The following is a description of a gene set: from publication Müller FJ, Laurent LC, Kostka D, Ulitsky I, Williams R, Lu C, Park IH, Rao MS, Shamir R, Schwartz PH, Schmidt NO, Loring JF (PMID 18724358) Stem cells are defined as self-renewing cell populations that can differentiate into multiple distinct cell types. However, hundreds of different human cell lines from embryonic, fetal and adult sources have been called stem cells, even though they range from pluripotent cells-typified by embryonic stem cells, which are capable of virtually unlimited proliferation and differentiation-to adult stem cell lines, which can generate a far more limited repertoire of differentiated cell types. The rapid increase in reports of new sources of stem cells and their anticipated value to regenerative medicine has highlighted the need for a general, reproducible method for classification of these cells. We report here the creation and analysis of a database of global gene expression profiles (which we call the 'stem cell matrix') that enables the classification of cultured human stem cells in the context of a wide variety of pluripotent, multipotent and differentiated cell types. Using an unsupervised clustering method to categorize a collection of approximately 150 cell samples, we discovered that pluripotent stem cell lines group together, whereas other cell types, including brain-derived neural stem cell lines, are very diverse. Using further bioinformatic analysis we uncovered a protein-protein network (PluriNet) that is shared by the pluripotent cells (embryonic stem cells, embryonal carcinomas and induced pluripotent cells). Analysis of published data showed that the PluriNet seems to be a common characteristic of pluripotent cells, including mouse embryonic stem and induced pluripotent cells and human oocytes. Our results offer a new strategy for classifying stem cells and support the idea that pluripotency and self-renewal are under tight control by specific molecular networks. studied in species Homo sapiens Human Gene Set: MUELLER_PLURINET Genes constituting the PluriNet protein-protein network shared by the pluripotent cells (embryonic stem cells, embryonical carcinomas and induced pluripotent cells)., and this is the list of marker genes: ARID3B, MNAT1, STRBP, GDF9, BYSL, RAD54L, PLSCR1, APOE, NUDT1, RFC4, NCL, POU5F1, CTBP2, MYB, TRIP13, PXN, SNRPE, PTPN6, TNNI3, HSPA8, TP53, MCM2, NPM1, NME1-NME2, PFDN6, NTAQ1, VAMP8 (vesicle associated membrane protein 8), ARMC6 (armadillo repeat containing 6), GRB7, MTHFD1, RUVBL1, MATK, RAD9A, KPNB1, LSM6, SMARCAD1, CHEK1, PARP1, EXOSC3, BRIX1, NLE1, MT1G, FBP1, BLM, DDX11, GAR1, SRSF3, POLQ, SYNCRIP, PHGDH, NTHL1, LUC7L3, H2BC4, SP1, STIP1, PFN1 (profilin 1), PCYT1B, BAK1, STXBP2, EPPK1, SNRPC, HPRT1 (NCBI Gene Id 3251), CCND1, MRPS12, PNN, WEE1, CKS1B, TDP2, MYC, CCNE1, DNMT3B, NUP50, NANOG, PSME3, DCTPP1, FUBP1 (far upstream element binding protein 1), OTX2, NOP56, ERBB3, HMGA1, ZNF281, EXOSC7, PNP, PCNA, WDR33, TUBA3C, LCK, CCNB1, TARBP2, SPAG5, PBX1 (NCBI Gene Id 5087), ZNF165, ERCC5, UNC119, MSH2, MCM6, GTF2H2, PSMA3, FOXO4, PSIP1, EWSR1, RMND5B, RPA2, PTMA, MCM3, SNRPN, POLR1D, EXOSC8, FKBP3, CDA, MYBBP1A, COIL, SNURF, TGIF1, PPM1B, CASP6, COPS3, DSCC1, FBL, TCOF1, PALS2, PA2G4, CDT1, ZNF593, HSPA9, DHFR, LSM1, ANAPC1, HAUS1, ORC1, GMNN, NPPB, KPNA2, PAK1, APEX1, GNL3, SEPHS1, POLR1C, GMPS, SIRT1, U2AF1, PRMT5, LRIF1, NOC2L, POP5, BUB1B, RFC5, COPS6, SNRPA, HSPA14, RAD51, BAG6, HDAC2 (NCBI Gene Id 3066), SMNDC1, CDC25C, CDK7, ANP32A, GPRIN2, DAXX, SNRPB, ANXA2, SRSF2, PAK3, RASL11B, RFC2, STXBP3, DAZAP1, MYBL2, WDR77, RBM14, MBD2, POLG2, TCERG1, SOCS1, MUTYH, GEMIN7, SUPT3H, ANXA3, RPA1, DPPA2, CEBPZ, TOE1, PPAN, RND1 (NCBI Gene Id 27289), HMMR, EXOSC9, ARL4A, HMGB1, HNRNPK, ITGB3BP, PHF10, ATIC, TNFRSF8, BIRC5, POP7, LSM4, PMF1, DIAPH1, CASP9, BCL2, MRM3, PMAIP1, EXO1, SSB, CXADR, CDC7, NME1, MCM10, MSH3, PLPP2, CRIPTO, AIMP2, ORC6, RECQL4, ACTA1, GOT2, HSPD1, GEMIN6, CDK1, CCNB2, TK1, MRE11, CCNA2, SNRPF, ELAC2, ZFP42, SUMO1 (small ubiquitin like modifier 1), SNRPD1, FAM136A, POLD1, DHCR24, TRIM28, PPID, LSM7, PASK, ORC2, KIT, RCHY1, TPX2, AURKA, HSPH1, PSMA6, LSM5, RFC3, PRNP, PHC1, CDC45, MCM5, SRSF1, HSP90AB1, KAT7, BIK, BCCIP, WRN, HDAC1, MSH6, STX3, SIGLEC12, SMN1, SALL4, AURKB, TMSB4Y, NUP153, MCM4 (NCBI Gene Id 780917), PIAS2 (protein inhibitor of activated STAT 2), LSM3, SET, PHB1, HNRNPAB (heterogeneous nuclear ribonucleoprotein A/B), RPP40, FEN1, RBPMS, SMARCC1, HSPA2, AATF, FUS, SLC19A1, GADD45A, HSPE1 (heat shock protein family E (Hsp10) member 1), CHEK2, NACC1, WRAP73, POLD2, TMPO, XRCC5, CENPE, PSMD11, NOLC1, PELP1, POP1, TRAIP, UNG (uracil DNA glycosylase), CKS2, GEMIN2 (gem nuclear organelle associated protein 2), VASP, RPA3, NFKBIB, NOP58, CHAF1A (NCBI Gene Id 107985297)